The following is a description of a gene set: species: Homo sapiens Subdural hemorrhage Human Gene Set: HP_SUBDURAL_HEMORRHAGE Hemorrhage occurring between the dura mater and the arachnoid mater., and this is the list of marker genes: ERCC8, ITGA2B, DNM2, ZFX, FGA, ACTA1, F8, MMACHC, GCDH, FGG, FGB, ERCC6, BICD2, RBM10, STT3A